The following is a description of a gene set: Genes predicted to be targets of miRBase v22 microRNA hsa-miR-182-3p in miRDB v6.0 with MirTarget v4 prediction scores > 80 (high confidence targets). species: Homo sapiens from publication Chen Y, Wang X (PMID 31504780) Human Gene Set: MIR182_3P, and this is the list of marker genes: ANKRD50, CRIM1, FRMD6, SLC25A24, FRMD5, CLVS1, C2CD6, FAT1, CREM, ZNHIT6, PIK3C2A, FAM107B, BDKRB2, KLHL15, HLA-DQA1, ZNF622, PERP, SLC30A4, LINC02898, RALGPS1, TMEM164, AMMECR1, SMIM12, TMEM26, RAPGEF6, B4GALT1, ARID5B (NCBI Gene Id 84159), NCAPG, METTL4, HDHD2, MRPL13, PWWP3B, ICA1L, CARD16, TTC13, DOCK9, SLC39A11, CELF2, EIF4H, RNF6, FYCO1, RBM46, IL6ST, CADM1, PPTC7 (protein phosphatase targeting COQ7), FBXO45, PHACTR2, CPA4, ZPBP2, ONECUT2, HLA-A, TRIM44, CCDC93, UBN1, CASP3, C5orf47, POU2F1, POLM, FEZ2, NAP1L1, PHACTR1 (phosphatase and actin regulator 1), LTBP2, PCDH17, G6PC2, RBMS3, GINS3, CXXC5